The following is a description of a gene set: Genes having at least one occurrence of the motif NGNNATTTCCSGGAARTGNNN in the regions spanning 4 kb centered on their transcription starting sites. This matches the STAT3 transcription factor binding site V$STAT3_01 (v7.4 TRANSFAC). Human Gene Set: STAT3_01 studied in species Homo sapiens, and this is the list of marker genes: ICAM1, BTBD1, HNRNPR, VIP, GEN1, CREBRF, PROS1, APBA1, ELMO1, ASXL1, IRF1, SERPING1, SLC38A5, CISH, UBR1, CCL2, ZNF112, TRAF4, SDHAF2, MAFF, IFT43, CLDN5